Given this list of marker genes Wdr44, Adgb (androglobin), Pabpc4, Rab2a, Bmx, Emc7, Arfgef1 (ADP ribosylation factor guanine nucleotide exchange factor 1), Bhlhe22, Pdp1, Srsf6, Tmem167, Heph, Stk16, Lin7a, Ereg, Mtmr4, Ms4a4b, Ncbp2, Lcorl, Vmn1r71, Zfhx3, Nipal1 (NCBI Gene Id 70701), Slc24a5, Gm14295, Anapc10, Frmd4b (FERM domain containing 4B), Zeb2 (NCBI Gene Id 319891), Pkp4, Ednra, Wnk1, Ppwd1, Mier3, Rfesd, Slc18a3, here is a description of the gene set: Genes predicted to be targets of miRBase v22 microRNA mmu_miR_215_5p in miRDB v6.0 with MirTarget v4 prediction scores > 80 (high confidence targets). from publication Chen Y, Wang X (PMID 31504780) Mouse Gene Set: MIR_215_5P species: Mus musculus